The following is a description of a gene set: from publication Ochiai K, Maienschein-Cline M, Simonetti G, Chen J, Rosenthal R, Brink R, Chong AS, Klein U, Dinner AR, Singh H, Sciammas R (PMID 23684984) Temporal analysis of B cell activation in vitro using CD40L and IL-2/4/5 cytokines in wild type Irf4+/+ B cells or in mutant Irf4-/- B cells harboring a tet-inducible allele of Irf4. IRF4 expression was restored, or not, in the Irf4-/- background by culturing in the presence of low or high concentrations of doxycycline. The results provide insight in the role of IRF4 expression levels in coordinating different programs of B cell differentiation. Genes up-regulated in CD40L and IL-2 IL-4 IL-5 stimulated at day 1 B cell IRF4high versus CD40L and IL-2 IL-4 IL-5 stimulated at day 1 B cell IRF4intermediate. studied in species Homo sapiens Human Gene Set: GSE46606_IRF4HIGH_VS_IRF4MID_CD40L_IL2_IL5_DAY1_STIMULATED_BCELL_UP, and this is the list of marker genes: IFT140 (intraflagellar transport 140), RNF138, EIF2AK3, NFX1, HPCAL1 (NCBI Gene Id 96763), DESI1, ELOVL6, DOCK11, HPS4, SIN3A, ABCE1, ZC3H12D, SMAP2, ZBTB44, NEIL1, XPO7, CCDC117, COMMD3, SS18, L3MBTL2, RASA1, PRKACB, PTS, TBC1D14, PLS3, MYO18A, KLRD1, WDR7, DUSP3 (NCBI Gene Id 284066), CNOT8, POLG2, C11orf54, CDK8, BIN3, TOP2B, SNAI3, UBL3, MAP2K7, RPUSD4, SLC44A2, GPHN, ATG2A, RB1, APOF, STK10, VPS37B, TPPP3, GBE1, WDR26, TLK1, ATG16L2, TXN2, MATR3, TGFBR1, KLHL24 (NCBI Gene Id 79965), SH3TC1, RBL2, HNRNPK, NCALD, RMND5A, SLC9A9, PON2, SMPD1, HSD17B8, REV1 (NCBI Gene Id 51455), NRM, UBN1, LAX1, VPS16, TCP11L2, SEPTIN6, ETS1, FOS, UBE3B, NAP1L4, ZNF141, MOCS3, RFC1, GRAMD1A, TDP2, OLFM4, MOB2, SLC41A1, UNC119, ERBB3, FARP2, RAB11FIP2 (RAB11 family interacting protein 2), ITGB3, QTRT1 (queuine tRNA-ribosyltransferase catalytic subunit 1), PEBP1, DGKZ, ERMP1, SH2B2, SASH3, PNPO, ACBD5, RSL1D1, PAXIP1, CHST15, KLHL21, NIF3L1, NUP107, POC5, FAM98C, LPIN1, CAPN7, AKAP8L, ACSL1, ZRSR2 (zinc finger CCCH-type, RNA binding motif and serine/arginine rich 2), TBXA2R, TSNAX, FBXO33, TSC22D1, KLHL6, ELF2, PDP1, SLC25A51, TMEM9B, TCF19, ATP23 (NCBI Gene Id 91419), IFNGR1, EXOSC7, RTF2, ZXDB, RUNX2, HAGHL, NIPAL3, POLDIP2, AXIN1, HVCN1, DYM, CDKN2AIP, PCMTD2, EVI5, SH3GLB2, CDC42SE2, PDE12, BCR, ABI3, RMND5B, TUBGCP5, SMARCA2, RGS2, CKB, GPR137B, BBS5, TIMM9, SH3PXD2A, NAGA, GNPTAB, CTPS1, RNF141, TM7SF2 (transmembrane 7 superfamily member 2), STX5, RALGDS, POLD1, IRF4, KLHL15 (NCBI Gene Id 80311), PSTK, AGO1 (NCBI Gene Id 26523), MAP4K1, TXNDC11, AGO4, SPSB3, ALKBH2, VSIR, PDCD2, PPM1A, GINS4, ZNF706, METTL23, MEF2A, GNE, CREB3L2, SERP1, BORCS6, CLCN4, RBM18, CSNK1E, SLC38A1, PANX1, SLA2, KCNN4, CCNY, RNF181 (ring finger protein 181), RBAK, TRAPPC5, CTDSP2, SLC9A6, TNFAIP8, TM2D3, ANAPC7, ACAP2, SPIN1, CD28, FBXO22, PPP1R21, ATG10, PPP5C, WBP1